Given this list of marker genes ARG1, HES1, RB1 (RB transcriptional corepressor 1), GADD45A, IL6, DUSP5, SERPINB5, SELE, TH, FOS (Fos proto-oncogene, AP-1 transcription factor subunit), PPARGC1A, JUND, RUVBL2, CCND1, MAPK9, EP300, ATF3, CSRP2, MAPK11, INS (insulin), NOS2, DUSP8, ATF2, PDGFRA, BCL2L1 (NCBI Gene Id 598), CXCL8, MACROH2A1, CBFB, MAPK14, ESR1, MAPK1, KAT5, JUN, JUNB, IFNG, BCL2 (NCBI Gene Id 596), DUSP10, CUL3, PRKCA, ACHE, IL23A, CDK4, MAPK3, HBG2, MAPK8, MMP2, TGFB2, NF1, COL24A1 (NCBI Gene Id 255631), DUSP1, CREB1, PLAU, SOCS3, CCNA2, JDP2, POU2F1, DDIT3, HRK, BRCA1, here is a description of the gene set: from publication Schaefer CF, Anthony K, Krupa S, Buchoff J, Day M, Hannay T, Buetow KH (PMID 18832364) ATF-2 transcription factor network Human Gene Set: PID_ATF2_PATHWAY species: Homo sapiens